The following is a description of a gene set: Human Gene Set: GOBP_PHOSPHATIDYLINOSITOL_MEDIATED_SIGNALING The series of molecular signals in which a cell uses a phosphatidylinositol-mediated signaling to convert a signal into a response. Phosphatidylinositols include phosphatidylinositol (PtdIns) and its phosphorylated derivatives. studied in species Homo sapiens, and this is the list of marker genes: PLCG2, PI4KB, PLCB3, PIK3CD, PIK3C2B, PIK3CA, PIK3CB, PLCL2, PLCH1, PIK3C3, PLCG1, PLCB4 (phospholipase C beta 4), PI4KA, PIK3CG, PLCL1, PLCB1, PIK3C2G, PLCB2, FGFR1, PLCE1, PLCH2, INPP5F, PIK3C2A, RPS6KB1